The following is a description of a gene set: species: Homo sapiens Human Gene Set: HP_ELEVATED_HEMOGLOBIN_A1C An increased concentration of hemoglobin A1c (HbA1c), which is the product of nonenzymatic attachment of a hexose molecule to the N-terminal amino acid of the hemoglobin molecule. This reaction is dependent on blood glucose concentration, and therefore reflects the mean glucose concentration over the previous 8 to 12 weeks. The HbA1c level provides a better indication of long-term glycemic control than one-time blood or urinary glucose measurements. Elevated hemoglobin A1c, and this is the list of marker genes: ALMS1, LMNA, BSCL2, DMXL2, BLK, SLC5A2, PAX4, NEUROD1, HNF4A, GCK, WRN, HNF1A, YIPF5, CELA2A, ABCC8, MTX2, TRMT5, KLF11, NARS2, NSMCE2, BLM, INS, PLAAT3, PDX1, KCNJ11, APPL1, DNAJC3, CEL